The following is a description of a gene set: Any process in which a cell, substance or cellular entity, such as a protein complex or organelle, is maintained in a location and prevented from moving elsewhere. studied in species Homo sapiens Human Gene Set: GOBP_MAINTENANCE_OF_LOCATION, and this is the list of marker genes: CCL19, MORC3, XCR1, CD4, CORO1A, SLC25A23, SNCA, CLIC2, MIR93, TSPO, CAPN3, P2RX7, RIT2, SELENON, ANK2, DBN1, CASQ2, ARL2, TMED2, INSIG1, CCR5, CCR7, SRGN (NCBI Gene Id 5552), PRKACA, CHERP, VPS13A, LETM1, UBASH3B, FKBP1B, CXCL11, RANGAP1, SORL1, FASLG, CCL3, PDIA2, NPSR1, PML, KDELR3, CHCHD10, CEMIP, DHRS7C, SP100, MDFI, GP1BB, ABL1 (ABL proto-oncogene 1, non-receptor tyrosine kinase), PLCB4, F2, ARHGAP21, TOPORS, F2R, HTR2A, VPS13D, TRDN, ITPR3, TGFB1, SRI, LCK, POLR2M, PRKD1, PLCE1, GPER1, LTBP1, NRROS, PGR, MCOLN1, GPSM2, FKRP (NCBI Gene Id 79147), PLCB1, ITPR2, PDE4D, AKT1, FBN1, CACNA1S (NCBI Gene Id 779), FAM76B, METTL21C, SIRT1, BBS4, APLNR, PRKCE, PTPN6, LACRT, GP9, MIR133A1, PLCL1, NBL1, JPH2, KDELR1, RYR2, BAX, TMEM232, NGF, SLC8B1, APOE, HTR2B, CHD7, RYR3, CALM2, ARL2BP, HDAC3, HTR2C, SUPT7L, CYBA, IBTK, HAP1, TXN, PINK1, DRD2, CIZ1, NR5A1, HK1, HRC, THY1, GP5, ATP2A1, KCNK16, AKAP9, XCL1, CD19, DDIT3, ATP1A2, INSIG2, PLCH1, PKD2, DIAPH1, ATP7B, CXCL9, CXCL10, JPH1, PTK2B, RYR1, CCDC88A (coiled-coil domain containing 88A), HTT, DMD, ERO1A, CACNA1C, NOL3, FLNA, GOLPH3 (NCBI Gene Id 64083), PAFAH1B1, GP1BA, TRPM2, ITPR1, MICOS10-NBL1, CX3CL1, JPH4, P2RY6, SUN2, TAF8, CCL21, GAA, CALM1, TAF3, HSPA5, ANXA6, HK2, TBCCD1, PLN, CAMK2D (calcium/calmodulin dependent protein kinase II delta), SUN1, FREY1, MFSD8, SYNE1, ANK3, FBN2, PLCH2, CER1, F2RL3, ASPH, SPOUT1, VPS13C (vacuolar protein sorting 13 homolog C), PSEN1, ANKRD13C, TMEM38B (NCBI Gene Id 55151), RER1, HNRNPU, PLCG1, CALM3, PLCG2, GPAA1, LYN, LIME1, MIR1-1, NTSR1, DAND5, CALR, GSTO1, MTLN, GHITM, KDELR2, ITGB3, PARK7, IL13, PTPRC, PLCL2, PKP2, OS9, PLCB3, FKBP1A (FKBP prolyl isomerase 1A), CXCR3, TMEM38A, PLCB2, FGF2, JPH3, GSTM2, DRD1, SKP1, AKAP6, PDPK1, UVRAG, ASPM, TRPC1, CASQ1, CAV1, CDK5, ATG5, EPG5, BARD1, TPCN2, SLC8A1, BDKRB1, HSP90B1